Given this list of marker genes Smarca5, Chd2, Smarca2 (NCBI Gene Id 67155), Ino80, Cecr2, Smarca4, Rad54l2, Chd1l, Arid1a, Chd5, Chd6, Smarca1, Chd7, Chd4, Myd88, Ercc6, Chd3, Smarcad1, Chd1, Chd8, here is a description of the gene set: Mouse Gene Set: GOMF_ATP_DEPENDENT_CHROMATIN_REMODELER_ACTIVITY An activity, driven by ATP hydrolysis, that modulates the contacts between histones and DNA, resulting in a change in chromosome architecture within the nucleosomal array, leading to chromatin remodeling. studied in species Mus musculus